The following is a description of a gene set: species: Mus musculus Beta oxidation of octanoyl-CoA to hexanoyl-CoA Mouse Gene Set: REACTOME_BETA_OXIDATION_OF_OCTANOYL_COA_TO_HEXANOYL_COA, and this is the list of marker genes: Echs1, Hadh (hydroxyacyl-Coenzyme A dehydrogenase), Hadha, Acadm, Hadhb (NCBI Gene Id 93764)